The following is a description of a gene set: Human Gene Set: GOBP_RETINAL_PIGMENT_EPITHELIUM_DEVELOPMENT The progression of the retinal pigment epithelium over time, from its initial formation to the mature structure. The retinal pigment epithelium is the melanin-containing layer of cells between the retina and the choroid that absorbs scattered and reflected light and removes waste products produced by the photoreceptor cells. species: Homo sapiens, and this is the list of marker genes: IHH, MED1, NDP, TBC1D32, PAX2, TMEM135, MFSD2A, CLDN3, SLC38A8, CLDN19 (claudin 19)